The following is a description of a gene set: Human Gene Set: GOCC_APICAL_CORTEX The region that lies just beneath the plasma membrane on the apical edge of a cell. studied in species Homo sapiens, and this is the list of marker genes: INSC, PRKCZ, MYO5B, FABP2, TCHP, SPTBN5, SAPCD2